Given this list of marker genes PRKAR1A, POLA1, NNT, INSR (NCBI Gene Id 3643), PIK3CA, BAP1, AR, AKT1, SLC39A4, GNAS, SEMA3A, PNPLA6, LHB, NR5A1, TP53, GATA4 (GATA binding protein 4), ZNRF3, CEP112, SPRY4, TAC3, WDR11, NFKB2, CDKN2A, FGFR1, FSHR, DHH, NHLH2, STAR, KISS1, FGF17, HSD3B2 (NCBI Gene Id 3284), ZFPM2, CHD7, FGD1, DCAF17, SOX9, FSHB, LEPR, DMXL2, GCNA, ALMS1, CYP17A1, CPE, NR0B1, SMARCE1, TACR3, CYP11B1, TAF4B, PDGFB, POLR3A, LEP (leptin), NR3C1, ANOS1, SMO, TXNRD2, NDNF, SMARCB1, ZMYND15, PROKR2, VAMP7, DUSP6 (NCBI Gene Id 1848), WWOX, NF2, RBM28, SPATA22, CTNNB1 (catenin beta 1), POR, DHX37, WT1, SRY, MRAP, NSMF, CYP11A1 (cytochrome P450 family 11 subfamily A member 1), ESR1, NR2F2, CYB5A, HFE, FANCM, HS6ST1, SUFU, FKBP6, ALG6, PROK2, GNRHR, MC2R, FGF8, FEZF1, MAP3K1, SYCE1, MAB21L1, WNT4, B4GALNT1, LGR4 (NCBI Gene Id 55366), KISS1R, TRAF7, BMP6, TERT, GNRH1, MSH4, here is a description of the gene set: Human Gene Set: HP_ABNORMAL_CIRCULATING_ANDROGEN_LEVEL Abnormal circulating androgen level An anomaly in the blood concentration of an androgen, that is, of a steroid hormone that controls development and maintenance of masculine characteristics. The androgens include testosterone and Dehydroepiandrosterone. studied in species Homo sapiens